Given this list of marker genes PYGL, LTB4R, SLFN12, PAWR, CCL5, ZBTB20, PAFAH2, TFEC, ADA (adenosine deaminase), ANXA2, B3GALNT1, PLEK, VAV3, XDH, GIMAP8, NSD3, OLFM4 (NCBI Gene Id 10562), ITGA1, CASP4, ELL2, TRIM34, SELENOM, CACNA1H, SNTB1, PRG2, PRDM1, DSG2, AMY2B, AFP, HID1, GIMAP4, NFIL3, ZBP1 (NCBI Gene Id 81030), FRMPD2, NKG7, RMDN2, ITGAL, CD9, CCR2, CPEB3, RNF215, KDF1, ALCAM, MS4A1, TRGC1, GNAZ, CEP250, GRAMD1C, SLPI, PYHIN1, TNFRSF17, SCAMP1 (secretory carrier membrane protein 1), RGS18, SLCO3A1, VCAM1, RGCC, ID2, GATM, CACNA1S, TAF9B, SEMA4F, CFAP61, F2RL1, ISG20, MMP8, SPON1, PRKCQ, LTF, ELANE, GPR160, PRLR, SCART1, RTP4, ENPP1, CACNB3, CCND2, SERPINA3, CSTA, MS4A2, LRP12, BASP1, LPAR4, HMGN3, HDC, SH2D1A (SH2 domain containing 1A), DHRS3, CXCR6 (NCBI Gene Id 10663), RORA, KLRC1, EOMES, IRF6, IGF1R, TBC1D8, P2RY14, GPM6A, CDH2, OOSP2, RSPH1, FPR1, TMEM154, HOOK1, EAF2, RHOB, STEAP4, IL2RB, ARFGAP3, IL13RA1, C3, MMP9, TRDC, GDA, TGFBI, S100A8, GZMA, TTC39B, CERS4, EDEM1, TRGV11 (NCBI Gene Id 6985), PLAAT3, KIAA1217, MFSD4A, SIRPG, CD226, ZBTB16, ARMCX2, GPC1, CP, SPAG6, EPCAM, RAB32, CTSW, F2R, C7orf57, IL18RAP, TNS3, RRAS2, PTPRE, SLC41A2, TSPAN2, DCLRE1B, FOSL2 (FOS like 2, AP-1 transcription factor subunit), OSBPL3, IQGAP2, CD7, CD3G, IGSF6, LRG1, PLSCR1, CTTN, TPSB2, FOS, ST8SIA6, ENTPD1, SGMS2, ICOS, APP, KDELR3, CRYBA4, RAB3D, PLIN3, TBX21, LYZ, TENT5C, DNAJB14, GVINP1, TMEM176B, FGL2, CLDN7, ARHGAP6, CD28, SELENOP (selenoprotein P), RAPH1, LDHB, GBP6, ATP6V0A1, MGAM, PTPN22, LCN2, F13A1, GGH, CD177, CHST1, INPP4B, RHPN2, MVB12B, WIPI1, LTB (lymphotoxin beta), BSCL2, ZNF467, FARP2, SLCO4C1 (NCBI Gene Id 55385, solute carrier organic anion transporter family member 4C1), CD8B, CPE, ITPRIPL2, NBEA, ABI3BP, OXR1, ARL4C, ARMCX3, TMEM176A, SEC24D, SARAF, SQOR, CTSG, IFI16, GPR174, SLC25A24, HP, SMAD1, HBA2, MDFIC, SEMA4A, RECK, C15orf48, RNASE3, FAM219A, MYO1F, TMEM38B, CFP, KLRK1, CRELD2, RUNX2, IL18R1, ELOVL7, OLFM1, HLA-B, PGLYRP1, MAF, FSCN1, DSP, P4HA2, HSD11B1, CD3E, KIT, RGS13, FAM135A, C6orf136 (NCBI Gene Id 221545), AQP3, PON3, MPO, STAT4, PIK3CB (NCBI Gene Id 5291), FADS3, PLCB4, MCEMP1, RNF128, IFITM3, FYB1, CHIA, SLC16A5, TRBC2, CD3D, GRAMD1B, S100A9, GCA, PRTN3, CAMP, MEGF9, LILRB1, GPR183, CLEC4E, ITK, KHK, ARSG, FNDC3B, LAX1, GABRA4, CORO2B, KRBA1, OOSP1, TIAM1, ITGB5, TRIM5, UPP1, RASGRP3, KLRD1 (NCBI Gene Id 92677), here is a description of the gene set: species: Mus musculus Human Gene Set: BOYLAN_MULTIPLE_MYELOMA_C_D_DN Genes down-regulated both in group C and D of tumors arising from overexpression of BCL2L1 and MYC in plasma cells. from publication Boylan KL, Gosse MA, Staggs SE, Janz S, Grindle S, Kansas GS, Van Ness BG (PMID 17483317) Multiple myeloma is an incurable plasma cell malignancy for which existing animal models are limited. We have previously shown that the targeted expression of the transgenes c-Myc and Bcl-X(L) in murine plasma cells produces malignancy that displays features of human myeloma, such as localization of tumor cells to the bone marrow and lytic bone lesions. We have isolated and characterized in vitro cultures and adoptive transfers of tumors from Bcl-xl/Myc transgenic mice. Tumors have a plasmablastic morphology and variable expression of CD138, CD45, CD38, and CD19. Spectral karyotyping analysis of metaphase chromosomes from primary tumor cell cultures shows that the Bcl-xl/Myc tumors contain a variety of chromosomal abnormalities, including trisomies, translocations, and deletions. The most frequently aberrant chromosomes are 12 and 16. Three sites for recurring translocations were also identified on chromosomes 4D, 12F, and 16C. Gene expression profiling was used to identify differences in gene expression between tumor cells and normal plasma cells (NPC) and to cluster the tumors into two groups (tumor groups C and D), with distinct gene expression profiles. Four hundred and ninety-five genes were significantly different between both tumor groups and NPCs, whereas genes were uniquely different from NPCs in tumor group C and genes were uniquely different from NPCs in tumor group D. Similar to human myeloma, the cyclin D genes are differentially dysregulated in the mouse tumor groups. These data suggest the Bcl-xl/Myc tumors are similar to a subset of plasmablastic human myelomas and provide insight into the specific genes and pathways underlying the human disease.